The following is a description of a gene set: Chronic hepatitis species: Homo sapiens Human Gene Set: HP_CHRONIC_HEPATITIS Hepatitis that lasts for more than six months., and this is the list of marker genes: SKIC2, RFXANK, PGM1, RFX5, C4B, AIRE, CD40LG, HBB, RFXAP, ALMS1, IL21R (interleukin 21 receptor), CIITA